The following is a description of a gene set: Mutation-caused aberrant SNCA to VGCC-Ca2+ -apoptotic pathway. Pathway ID: N01031. Pathway type: Variant. Pathway class: nt06463 Parkinson disease. Pathway Definition from KEGG: Ca2+(extracellular) -- SNCA* -> Ca2+ -- MCU -> Ca2+(mito) -- MPTP -> CYCS == APAF1 -> CASP9 -> CASP3 Human Gene Set: KEGG_MEDICUS_VARIANT_MUTATION_CAUSED_ABERRANT_SNCA_TO_VGCC_CA2_APOPTOTIC_PATHWAY species: Homo sapiens, and this is the list of marker genes: SLC25A5, VDAC3, VDAC2, VDAC1, SLC25A6, CASP9, MCU (mitochondrial calcium uniporter), APAF1, CYCS, CASP3, SLC25A31, SLC25A4, SNCA